Given this list of marker genes NAALADL2, B4GALT6, SLC5A9, MAK16, CLEC4E, FAM204A, INO80D, CALHM4, RAB27B, RPS6KA6, PLP1, RAB21, C2orf78, MTMR12, STX7, MTX2, DGKH, AVPR1A, RALGAPA1, GNB4, TMEM106B, PROSER1, CLIC2, PHF3, ZNF616, CST3, RDH10, SPAST, PHYKPL, PTH, CCDC198, SULT1E1, LIPA, CAV1, G3BP2, TCEAL9, AICDA, LEPR, NR2F1, TGOLN2, LATS2, ALKBH8, GAPT, AFF2, GRHL1, DNM3, MBTD1, TFAP2B, SORL1, NXPE3, LNPK, AFG1L, EXD2, CARF, RBM25, SORBS1, ZNF804A, NEK2, MEX3C, SGPP1, CLDN22, GAB1, GPM6A, PDIK1L, TAF4B, YES1, FKBP9, PRKAA1, LSM8, SPRED1, SUCNR1, TSGA10, PRKACB, TRIM45 (NCBI Gene Id 80263), CRY1, RIMOC1, ZNF529, STARD5, INHBC, MCTS1, HACE1, KANK2, LPAR4, MDM4, ITGAV, GTF2A1, SESTD1, ZNF713, GORAB, PGBD1, C6orf58, NADK2, IL36G, here is a description of the gene set: species: Homo sapiens from publication Chen Y, Wang X (PMID 31504780) Genes predicted to be targets of miRBase v22 microRNA hsa-miR-3074-3p in miRDB v6.0 with MirTarget v4 prediction scores > 80 (high confidence targets). Human Gene Set: MIR3074_3P